Given this list of marker genes Lcn9, Apod, Slc27a1, Lcn12, Slc27a6, here is a description of the gene set: This event has been computationally inferred from an event that has been demonstrated in another species.<p>The inference is based on the homology mapping from PANTHER. Briefly, reactions for which all involved PhysicalEntities (in input, output and catalyst) have a mapped orthologue/paralogue (for complexes at least 75% of components must have a mapping) are inferred to the other species. Reactome Pathway: Transport of fatty acids electronically inferred by orthology from the curated human pathway species: Mus musculus part of: Transport of vitamins, nucleosides, and related molecules